Given this list of marker genes Nkapd1, Nsdhl, Lrch3, Inpp5e, Atp2a2, Clip4, Osbpl8, Rreb1, Gm17019, Acta2, Tmx1, Man1a, Phlpp1, Thbs2, Nrxn1, Rtn3, Loxl4, Psip1, Creb3l1, Zeb1, Pacsin1, Ap1s3, Rnf145, Api5, Ap1g1, Cbx5, Spata9, Triqk, Enpp2, Dcun1d2, Bend7, Rilp, Ythdc2 (YTH domain containing 2), Cenpi, Khdrbs1, Fam91a1, Slamf7, Ppp1r3b, Ror1, Ptprs, Sppl3, Mccc2 (NCBI Gene Id 78038), Slc16a1, Ing3, Ephx3, Samd9l, Crisp4, Lypla1, Rictor, Fam76b, Rbm44, Qrich1, Gpr50, Capn2, Slc37a3, Phf6, Fam227a (family with sequence similarity 227, member A), Aff4, Cdr1, Tank, Atxn7, here is a description of the gene set: Mouse Gene Set: MIR_654_3P studied in species Mus musculus Genes predicted to be targets of miRBase v22 microRNA mmu_miR_654_3p in miRDB v6.0 with MirTarget v4 prediction scores > 80 (high confidence targets). from publication Chen Y, Wang X (PMID 31504780)